Given this list of marker genes MYSM1, PRPF8, STAMBPL1, COPS6, STAMBP, PSMD14, PSMD7, BRCC3, EIF3H, EIF3F (NCBI Gene Id 8665), MPND, COPS5, here is a description of the gene set: species: Homo sapiens An metal-dependent isopeptidase activity that cleaves ubiquitin from a target protein to which it is conjugated. Human Gene Set: GOMF_METAL_DEPENDENT_DEUBIQUITINASE_ACTIVITY